The following is a description of a gene set: Abnormal erythrocyte morphology Any structural abnormality of erythrocytes (red-blood cells). Human Gene Set: HP_ABNORMAL_ERYTHROCYTE_MORPHOLOGY species: Homo sapiens, and this is the list of marker genes: MADD, ADA, FOXP1 (forkhead box P1), PROS1, SDHA, SP110, WRAP53, POT1, EPAS1, SURF1, UROD, MT-ND6, CP, FERMT3, MPL, TYMP, RPGRIP1L, RASGRP1, FAH, CYP27B1, ATP5F1A, ITPA, KIF15, JAK2, MYSM1, SLC4A1, RBCK1, KLF1, FANCE, MT-TW, FADD, MDM4, RPS19, TBXAS1, MT-ND4, ZAP70, CDCA7, KCNQ1, CYB561, POLG, NOP10, ZBTB16, STX11, PRKAR1A, COA8, TF, SLC25A38, DPP9, HAVCR2, PTPN6, EPHB4 (EPH receptor B4), NTRK1, USB1, ABCB7 (NCBI Gene Id 8252), THPO, CYB5R3, CD40LG, BPGM, FN1, FH, FARSB, IRF8, GCK, HBB, TP53, CARD10, SLC4A2, NABP1 (nucleic acid binding protein 1), SPTA1 (spectrin alpha, erythrocytic 1), SARS2, TBX1, GYPC, ABCB6, F2, RPL13, IFNGR1, RPL5, FBXL4, ASXL1, NLRC4, LRBA, TRNT1, CLPB, STIM1, COL4A1, PRKACG, KLF11, KHK, FARSA, QRSL1, RPL35, GATA2, STEAP3, RRM2B, SLC30A10, TNFRSF4, RPL18 (NCBI Gene Id 6141), IL37, ELF4, SBDS, KCNE1, ANAPC1, NEUROD1, FANCI, MT-ND5, TAFAZZIN, CBLB, CTLA4, TPI1, PRF1, GNA14, IL2RA, IL12B, LMBRD1, TNFAIP3, PHF21A, LIG4, ATP6AP1, VPS33A, ERBB3, FARS2, STAT3, HMGCL, FDX2, LAMB3, EPO, LCK, G6PD, SMARCAL1, RFX5, VHL, DNASE1, ANKRD11, GNB2, ETV6, ATIC, CR2, KCNJ11, CDAN1, GBA1, P4HA2, MMADHC, FAS, CARS1, CFHR3, ANK1, TCIRG1, INS, TBL1XR1, AASS, HBA1 (hemoglobin subunit alpha 1), GATA1, XRCC4, XRCC2, ACAD8, C3, NHP2, HLA-DRB1, SPP1, HBD, HBG2, GALE, MT-TN, KRT14, PLEC, PLAAT3, DKC1, ALG8, WRN, TTR, CAT, AMN, GALNT2, SLC12A3, NCAPG2, SDHC, DNMT3B, RPS7, FIP1L1, RPS27, DNAJC21, SUCLA2, CIITA, SMC5, ETS1 (NCBI Gene Id 2113), HPRT1, ALAS2, CUBN, UBA1, ABCC8, ALAD, SF3B1 (NCBI Gene Id 23451), REN, STXBP2, UMPS, PFKM, MT-ND1, JAZF1, FTH1, ZBTB20, NDUFB7, DNAJC3, FOXP3, PAX2, CELA2A, SLC30A7, IRAK1, PDX1, DPAGT1, DCLRE1C, APPL1, TSR2, CD55, DGKE, SLC11A2, CD59, FANCA, MMACHC, CYP2R1, TERT, GPI, FANCB, FANCF, NT5C3A, MPIG6B, ACVRL1, KCNE5, PGK1, BANK1, COX4I2, ADA2, MLX, PTF1A, ITGAM, PUS1, KCNN4, NSMCE2, GSR, PSMC1, RPS15A, SLC2A1, OPA1, LCP2, ERCC8, TFR2, PI4KA, KIF1B, RPS14, MMUT, STAT1, ABCD4, ORAI1, FMO3, NBN, HMBS, KIAA0319L, RAG2, RACGAP1 (Rac GTPase activating protein 1), LPIN2, HLA-DQB1, F8, ADH5, ACVR1, IL10, PML, XK, TMPRSS6, CLCN7, TLR7, RAD51C, PIK3CG, EDNRB, DOCK11, ICOS, DDX41, CFH, C2orf69, GATC (glutamyl-tRNA amidotransferase subunit C), APC, VPS13A, EGLN1, HLA-B, ZBTB7A, SEC23B, C4B, PLA2G4A, SPTB, SRP54, ELANE, UBE2L3, PLEKHM1 (pleckstrin homology and RUN domain containing M1), SLC25A13, PIK3CA, PSAP, UROS, PACS2, SLC25A10, ATPAF2, STAT4, SCARB2, IFNG, MPLKIP, DMXL2 (NCBI Gene Id 23312), UBE2T, NFKB1, LARS1, RPL31, GPX1, ACTN4, NPHP4, MS4A1, NPHP1, ZBTB24, SRD5A3, H19, HK1, RPL26, LYST, EWSR1, IKZF1, FAM111A (NCBI Gene Id 63901), SNX10, SEC61A1, PRDX1, PCNT, TNIP1, RPL11, TKFC, TNFSF4, NFKB2, MEFV, GLRX5, RPL15, IRF1, RAP1B, TCF3, WT1, NAA10, FOCAD, COL7A1, APOB, RBM8A, RHCE, ALMS1 (NCBI Gene Id 7840), IL6ST, HELLPAR, REST, TNFSF11, SMARCD2, GREM1, TBK1, SDHB, ALK, PEPD, ADAMTS13, RFWD3, IL7R, GTF2H5, HBA2, TRIP13, ABCG5, SLC7A7, IL2RG, CHD7, NSUN2, MT-TQ, VPS45, SASH3, TNFRSF13C, ARPC5, SRP68, LYZ, BRIP1, ACSL4, C1QB, UQCRFS1, SAMD9, IRF4, ABCD3, MT-CO2, SLF2, PDCD1, AGXT, PTEN, TFRC, COL2A1, THBD, TINF2, CISD2, BLK, MVK, RECQL4, FANCG (NCBI Gene Id 82603), CD19, THRA, CFI, RMRP, STAT5B, CCND1, SC5D, SRSF2, MMAB, TNFRSF11A, NPM1, PIEZO1, ENG, RUNX1, CPOX, CASP10, GATB, SH2B3, ERCC6, FECH, C1GALT1C1, YARS2, EPOR, LARS2, CYP4F22, TOR1A, MMAA, FTCD, MECOM, SFXN4, DEF6, KARS1, NUMA1, SLC29A3, TYMS, GTF2E2, RHD, ABCG8, PGM3, PHOX2B, CDIN1, NOD2, FCGR2A, MTTP, SLCO2A1, SLX4, PTPN22, BSCL2, RTEL1, KRAS, CYB5A, UNC45A (unc-45 myosin chaperone A), CDC40, ITK (IL2 inducible T cell kinase), GFI1B, PBX1, HELLS, BIRC3, PNP, LIPA, BLM, GALK1, YARS1 (NCBI Gene Id 8565), ALX4, CFHR1, DIS3L2, PHKA2, MTRR, COL17A1, LMNA, YIPF5, MT-TL1, ATRX, MT-TF, POLRMT, EPB42, IL2RB, DHFR, PDGFRA, RPL27, HGD, CBLIF, TRAC, RPS26, STK4, PSMB8, SLC19A2, GP1BA, SERPINA6, PSMB4, COL3A1, RIPK1, DNM1L, ERCC3, IRF2BP2, RAC2, FOXN1, KMT2D, NAF1, HSPA9, RPS20, SLC46A1, NEK8, STING1, WIPF1, AGGF1, RPS24, NRAS, ACP5, TET2, CFB, IRF5, SAMD9L, CEL, RPS28, ALG2, ALPL, SLC37A4, ITGA2B, UNC13D, HNF1A, ARG1, PHGDH, EIF2AK3, COX10, ATP11C, DIAPH1, CYBC1, MECP2, MYD88, GSS, SAT1, TNFSF12, GDF2, PNPO, OSTM1, KRT5, WFS1, PANK2, SLC5A2, GALT, FANCM, SHPK, CASR, PHKG2, RFXANK, CLCNKB, TALDO1, BCOR, SLC35C1, HPGD, OCRL, BMPR1A, HAMP, HNF4A (NCBI Gene Id 4339), TLR8, IFT140, PTPN2, TMEM67, PRPS1, KIT, COG1, RPL9, SMPD1, IFIH1, SAR1B, ASAH1, TNFRSF13B (NCBI Gene Id 23495), LIG1, TRMT5, TBCE, CAD, FANCC, LAT, FASLG, TCN2, BRCA1, LMO1, FANCL, MT-CO3, BRCA2, AK2, PSMG2, BTNL2, IGHG1, PSTPIP1, FERMT1, CTC1, PIGT, GCLC, ELMO2, RAD51, MUC1, MT-TH, BCL11A, CD247, CALR, RECQL (NCBI Gene Id 5965), MTX2, PHKB, C4A, PIGA, DBH, AK1, RNF31, FCGR2B, RPS10, ERCC4, RPS29, FLI1, LAMC2, ATP7B, CLPX, AARS1, CD46, MARS1, IREB2, SYK, MYCN, PALB2, ALDOA, HSCB (NCBI Gene Id 150274), MTR, SLC25A21, NLRP3, RAG1, CRIPT, ABCA1, MALT1, LIG3, EFL1, MT-CO1, HMOX1, HACE1, CD3G, FCGR3B, RPSA, ITGB4, PARN, DRG1, NHLRC2, DUT, GLA, G6PC3, DNAJC19, TARS1, CD81, POU6F2, HLA-DQA1, BCL10, HCK, SMAD4, PKLR, PLCG1, RPS17, TRIM28, ERCC6L2, KIF23, FANCD2, ERCC2, DCDC2, SLC19A1, ANKRD55, GPC3, NLRP1, MTHFD1, TTC7A (tetratricopeptide repeat domain 7A), LIN28B, RNF113A, PCCB, SLC40A1, EPB41, STK11, PRIM1, ISCU, CA2, NARS2, TERC, TPP2, NHEJ1, STAT2, RFXAP, LYRM7, EXT2, RPL35A, RARA, RHAG, HEATR3, AMMECR1, TREX1, RNU7-1, HBG1, PXK, TEK, PCCA, SOCS1 (suppressor of cytokine signaling 1), UBR1, LAMA3, UHRF1, BTK, TGFB1, LCAT, RPL8, MAD2L2, CBL (NCBI Gene Id 867), ADAR, LYN, MMP1, ZNF699, FGF23, CASK, COQ2, PRKCD (NCBI Gene Id 5580), PPOX, ACD, WAS, MT-TS2, KDM6A, PAX4, IRX5